The following is a description of a gene set: Prolonged bleeding after dental extraction Prolonged bleeding post dental extraction sufficient to require medical intervention. Human Gene Set: HP_PROLONGED_BLEEDING_AFTER_DENTAL_EXTRACTION studied in species Homo sapiens, and this is the list of marker genes: F2, F8, LMAN1, SERPINE1, DTNBP1, TPM4, FGA, F11, GP1BB, MCFD2, F10, FGB, F7, F5, F13A1, APOLD1, FGG, GP9, RASGRP2, ITGB3, GP1BA, F13B, VWF